Given this list of marker genes GBF1, BBS1, AP3S2, RAB13, ARFRP1, KRT18, RAB14, AP1G2, DOP1B, BBS2, AP1AR, EPS15, DOP1A, SCAMP2, STXBP5, RACK1, RP2, GOPC, ACSL3, EXOC6, LLGL2, VAMP4, CNST, LYPLAL1, EHD3, GOLPH3L, SORCS1, BLZF1, DNM2, AP3D1, ANXA13, RBSN, PKDCC, OSBPL5, RAB3IP, VPS13A, RAB34, GGA2, VPS54, AP2A1, WIPI1, RSC1A1, AMN, AP3S1, SPTBN1, VPS35L, STXBP5L, ATP2C1, GGA3, SCAMP1, EXOC8, CSK, VTI1A (vesicle transport through interaction with t-SNAREs 1A), EXOC4, RABEP1, VAMP2, CLN3, PHAF1, ANK3, MON2, VPS52, RAB11A, MYO5A, LLGL1, KLHL20, LYPLA1, KIF16B, VAMP3, NSF, RAB11FIP3, EXOC6B, SCFD1, OPTN, RAB26, SCAMP3, LAMP1, CCDC22, CORO7, AP1G1, EXOC5, AP4M1, CCDC91, STEAP2, SYS1, ARFGEF2, COMMD1, MACF1, SORL1, VAMP5, EXOC2, RABIF, GAK, GOLGA7, KIF13A, RAB10, ARL3, ANKFY1 (ankyrin repeat and FYVE domain containing 1), LAPTM5, SEC16A, SNAP23, GGA1 (golgi associated, gamma adaptin ear containing, ARF binding protein 1), CCDC93, SORT1, PREPL, RAB31, MYO1B (myosin IB), EXOC1, VTI1B, VPS13C, GOLGA4, GCC2, GOLPH3, here is a description of the gene set: The directed movement of substances from the Golgi to other parts of the cell, including organelles and the plasma membrane, mediated by small transport vesicles. studied in species Homo sapiens Human Gene Set: GOBP_POST_GOLGI_VESICLE_MEDIATED_TRANSPORT